Given this list of marker genes Calm1, Pkd2, Selenon, Hrc, Jsrp1, Jph2, Gsto1, Calm2, Gstm7, Calm3, Fkbp1b, Sri, Pln, Fkbp1a, Jph3, Casq2, here is a description of the gene set: species: Mus musculus Mouse Gene Set: GOBP_REGULATION_OF_RYANODINE_SENSITIVE_CALCIUM_RELEASE_CHANNEL_ACTIVITY Any process that modulates the activity of a ryanodine-sensitive calcium-release channel. The ryanodine-sensitive calcium-release channel catalyzes the transmembrane transfer of a calcium ion by a channel that opens when a ryanodine class ligand has been bound by the channel complex or one of its constituent parts.